Given this list of marker genes MAPK1, GNG10 (G protein subunit gamma 10), GNGT2, ARRB1, GNA11, GNB1, GNG13, GNG3, F2RL3, SRC, GNG12, ARRB2, F2R, GNA13, GNA12, GNB3, GNA14, GNG7, GNG2, GNG8, GNA15, GNB2, GNG4, F2RL2, GNG11, MAPK3, GNAQ, GNG5, F2, GNB5 (G protein subunit beta 5), GNGT1, GNB4, here is a description of the gene set: studied in species Homo sapiens Thrombin signalling through proteinase activated receptors (PARs) Human Gene Set: REACTOME_THROMBIN_SIGNALLING_THROUGH_PROTEINASE_ACTIVATED_RECEPTORS_PARS